Given this list of marker genes Nktr, Ppif, Ppie, Ppihl, Ppwd1, Ppic, Ppia, Ppig, Ppp3r1, Ppih, Ppil1 (NCBI Gene Id 68816), Ppp3ca, Ppid, Ppib, here is a description of the gene set: Binding to cyclosporin A, a cyclic undecapeptide that contains several N-methylated and unusual amino acids. studied in species Mus musculus Mouse Gene Set: GOMF_CYCLOSPORIN_A_BINDING